Given this list of marker genes BHLHE40, BHLHE41, KLF5, KDM1A, CREBBP, here is a description of the gene set: species: Homo sapiens Human Gene Set: GOMF_MRF_BINDING Binding to Myogenic Regulatory Factor (MRF), a member of the basic Helix-Loop-Helix (bHLH) superfamily of transcription factors.